The following is a description of a gene set: Reduction of cytosolic Ca++ levels Mouse Gene Set: REACTOME_REDUCTION_OF_CYTOSOLIC_CA_LEVELS species: Mus musculus, and this is the list of marker genes: Calm3, Atp2a3, Slc8a2, Calm1, Atp2a2, Slc8a3, Atp2b2, Calm2, Atp2b1, Atp2a1, Atp2b4, Slc8a1, Atp2b3, Sri